The following is a description of a gene set: species: Homo sapiens The process in which a relatively unspecialized mesodermal cell acquires the specialized structural and/or functional features of a cardioblast. A cardioblast is a cardiac precursor cell. It is a cell that has been committed to a cardiac fate, but will undergo more cell division rather than terminally differentiating. Human Gene Set: GOBP_CARDIOBLAST_DIFFERENTIATION, and this is the list of marker genes: REST, RBPJ, PRICKLE1, MYOCD, NOTCH1, EOMES, NKX2-5, EEF1AKMT4-ECE2, ITGB1, TBX5, GREM1, TGFB2, DHX36, NRG1, ISL1 (ISL LIM homeobox 1), TBXT, TBX2, SRF